Given this list of marker genes Sox18, Ihh, Tmed2 (transmembrane p24 trafficking protein 2), Dnaaf1, Ryr2, Gja1, Hif1a, Setdb2, Rnf207, Arl13b, Mib1, Hes1, Tbx3 (NCBI Gene Id 52240), Nodal, Fgf8, Dll1, Sox17, Aldh1a2, Zic3, Hhex, Ece1, Tbx20 (NCBI Gene Id 77243), Dvl2, Rbpj (NCBI Gene Id 791349), Notch1, Srf, Ccdc39, Shh (NCBI Gene Id 20423), Hand1, Kif3a, Tmem94, Ift122, Vangl2, Foxn4, Yap1, Gata4, Aplnr, Dvl1, C2cd3 (C2 calcium-dependent domain containing 3), Megf8, Foxc2, Pitx2, Tead1, Sufu, Apela, Invs, Smad3 (NCBI Gene Id 17127), Hand2, Ift57, Cimap3, Traf3ip1, Noto, Cluap1, Ift52 (intraflagellar transport 52), Lbx1, Pcnt, Kdm2a, Notch2, Psen1, Mesp1, Nkx2-6, Acvr1, Greb1l, Nckap1, Gja5, Eng, Wnt5a, Stil, Chrd, Plxna4, Ccdc103, Nkx2-5, Ednra, Smo, Tgfbr2, Slc8a1, Mef2c, Ovol2, Ift172, Pkd2, Wnt3a, Ctnnb1, Cited2, Tbx2, Ccdc40, Folr1, Cdc42, Mical2, Tead2, Nphp3, Lrp6, Asb2, Edn1, Med1, Foxc1, Cfc1, Foxh1, here is a description of the gene set: species: Mus musculus Mouse Gene Set: GOBP_EMBRYONIC_HEART_TUBE_DEVELOPMENT The process whose specific outcome is the progression of the embryonic heart tube over time, from its formation to the mature structure. The heart tube forms as the heart rudiment from the heart field.